The following is a description of a gene set: Any structural anomaly of the lower motor neuron. Abnormal lower motor neuron morphology Human Gene Set: HP_ABNORMAL_LOWER_MOTOR_NEURON_MORPHOLOGY species: Homo sapiens, and this is the list of marker genes: CHMP2B, MATR3 (matrin 3), SQSTM1, PLEKHG5, C9orf72, TREM2, ATXN3, SPG11, VPS41, CHCHD10, FUS, TARDBP, TBK1 (TANK binding kinase 1), VPS13D, PSEN1, ALS2, TMEM106B, SETX, VCP, SPG7, MAPT, C19orf12, DCTN1, GRN, ASAH1, TRPM7